The following is a description of a gene set: species: Homo sapiens Any process that stops, prevents or reduces the frequency, rate or extent of phospholipid metabolic process. Human Gene Set: GOBP_NEGATIVE_REGULATION_OF_PHOSPHOLIPID_METABOLIC_PROCESS, and this is the list of marker genes: MIR30C1, LPIN1, LPCAT1, PDGFB, PDGFA, ABCA2, APOC1